The following is a description of a gene set: Genes having at least one occurrence of the motif TGARCCYTTGAMCCCW in the regions spanning 4 kb centered on their transcription starting sites. This matches the PITX2 transcription factor binding site V$ARP1_01 (v7.4 TRANSFAC). species: Homo sapiens Human Gene Set: ARP1_01, and this is the list of marker genes: HTR1B, GLI1, TREML2, SZT2, CELF3, MORF4, C1QTNF7, SERPINC1, SLC25A35, TMEM150A, AGFG2, MYOCD, NDST2, POU3F4, NR6A1, ALDOA, BMP5, FGF20, STAR, AP1B1, SKIL, RALY, ADGRA2, RIN1, ZNF532, LYRM1, CCN2 (cellular communication network factor 2), TXNDC12, CDK5R1, CTLA4, A1CF, B3GALT2, AZIN1, SLITRK6, DLG2, MICU2, APOM, CHD2, CDX1, HOXA1, TRERF1, MMP28, HEPACAM, CPNE1, ZNF644, ESRRG, NR5A2, NXPH1, ZFX, ZBTB20, PDZRN4, PDGFB, NKAIN3, CDC37L1, HOXD4, IRAK1, WDR81, PARP16, MIR9-1HG, CYP2E1, ACKR3, GATA1 (NCBI Gene Id 2623), PMF1, MLLT6, IL11RA, CFL2, ARHGEF15, POMP, SLC12A5, MAB21L2, ELF4, NFE2, C1orf21, JPH1 (NCBI Gene Id 56704), C1orf116, MYL1, EMP1, IL21, TMEM255A, NALF2, ZNF516-DT, PIK3CG, RIPOR2, CAMKV, MIDEAS, ZNF711, HAPLN1, LINC01138, RRAGD, BAHD1, PKP3, CCDC6, PPM1E, E2F4, TOGARAM1, CASK, PROP1, TRIM69, CRYGC, EXOC3L1, FCHSD2 (FCH and double SH3 domains 2), MIR22HG, SORBS1, RBBP6, KIRREL2, SLITRK1, KIF13A, AQP7, MNAT1, DNAJC5B, JADE1, RUNX3, HSPB8, ZNF205, ZHX2, PLK3, DLX1, RUNX1T1, OTX2, SMARCC2, CFI, FOXP2, DBP, TMIGD1, TSSK4, ARR3, C1QTNF5, ARL4C, MARCKSL1, PITPNC1, KLHL28, ASB12, CLDN15, FCHSD1, TMEM164, GPR3, SLC7A8, TRAF4, MRPS18B, MED8, RNF34, DLX5, POLD4, MVB12A, ZSWIM8, NFIX, OMD, ZFHX3, DMD, RASIP1, SPARC, LTBP3, COL16A1, FBXL20 (NCBI Gene Id 90110), SIPA1, TMEM256, HOXA3, TGIF2, ATP2C1, CACNA1G, ATF7IP, TGFB3, PPFIA3, ENSA, C19orf73, NLK, HPCA